The following is a description of a gene set: Human Gene Set: GSE3920_UNTREATED_VS_IFNA_TREATED_ENDOTHELIAL_CELL_DN studied in species Homo sapiens IFNs are highly pleiotropic cytokines also endowed with marked anti-angiogenic activity. In this study, the mRNA expression profiles of endothelial cells (EC) exposed in vitro to IFN-alpha, IFN-beta, or IFN-gamma were determined. We found that in HUVEC as well as in other EC types genes were upregulated (>2-fold increase) by IFNs, including genes involved in the host response to RNA viruses, inflammation, and apoptosis. Interestingly, genes showed a >5-fold higher induction by IFN-alpha in EC compared to human fibroblasts; among them, the gene encoding the angiostatic chemokine CXCL11 was selectively induced by IFN-alpha in EC along with other genes associated with angiogenesis regulation, including CXCL10, TRAIL, and guanylate binding protein 1 (GBP-1). These transcriptional changes were confirmed and extended by quantitative PCR analysis and ELISA; whereas IFN-alpha and IFN-beta exerted virtually identical effects on transcriptome modulation, a differential gene regulation by type I and type II IFN emerged, especially as far as quantitative aspects were concerned. In vivo, IFN-alpha-producing tumors over-expressed murine CXCL10-11, GBP-1 and TRAIL, with evidence of CXCL11 production by tumor-associated EC. Overall, these findings improve our understanding of the anti-angiogenic effects of IFNs by showing that these cytokines trigger an anti-angiogenic transcriptional program in EC. Moreover, we suggest that quantitative differences in the magnitude of the transcriptional activation of IFNresponsive genes could form the basis for cell-specific transcriptional signatures. from publication Indraccolo S, Pfeffer U, Minuzzo S, Esposito G, Roni V, Mandruzzato S, Ferrari N, Anfosso L, Dell'Eva R, Noonan DM, Chieco-Bianchi L, Albini A, Amadori A (PMID 17202376) Genes down-regulated in ndothelial cells: untreated versus interferon alpha., and this is the list of marker genes: KCNK2, PDE2A, PPA1, TMEM154, HARS2, HELZ2, TCOF1 (treacle ribosome biogenesis factor 1), CEP57, CD5, RPL3, DBR1, POLG2, FAM193B, TBC1D16, ATP10A, JAKMIP1, PNPT1, TARS1, ANXA6, LEF1, IL12RB2, NRM, STARD4, ASRGL1, DAXX, TOP2A, LY6D, ELOVL5 (NCBI Gene Id 60481), IFIH1, SPNS3, EZH2, ABTB3, NUDT21, SEC11A, CD69, ZDHHC20, ACSS3, RDH13, ZEB1, LSM14A, NEMP2, PAIP2B, MRPL30, FLNA, TTC39C, GZMM, ANP32E, PRMT5, GABBR1, INO80, RYK, NR3C1, TAF15, JTB, CRYBB3, ETNPPL, SPATA6, FAM53B, GPSM2, IQGAP2, TOMM20, MBNL3, STAT4, GMCL1, IMMP2L, XAF1, FHIP1B, IAPP, PPAT, FNTB, ARHGAP19, IFNGR1, ASB13, SLC7A6, TUFT1, SLAMF1, ZBTB33, SMC3, MAN2A2, TCF12, TBRG1, SLC6A7, ADGRE5, MKI67, CMTR1, MYL4, SETDB2, RPL19, GNAS, ITGB1, CLEC3B, EFHC2, PATJ, KCTD10, NONO, MCM5, SIGLEC15, GTF2I, SMS, ATM (ATM serine/threonine kinase), SLC38A2, KMO, PHF2, DNTT, FLNB, SIT1, ZC3H14, B3GNT2, SEC16B, ATG16L1, NANOS2, POU6F1, ITGB3, SLC14A2, BTLA, EPRS1, SOS1, MPPE1, KRTAP5-1, CDX1, BZW2, PLSCR4, TTC7B, RBBP6, ENTPD5, GFI1, KIRREL2, EVL, XPO7, POLE2, ITPR1 (inositol 1,4,5-trisphosphate receptor type 1), ZHX2, IFIT1, IARS1, HERPUD1, SLC38A8, BBS10, BTBD10 (BTB domain containing 10), TAPT1, MFSD2A, RASGRP1, EMB, MSS51, USP24, ZNRF1, CD82, TMEM150A, LHFPL6, MCM6 (minichromosome maintenance complex component 6), COX6A2, HGSNAT, RORA, CDK5RAP3, RINT1, HOPX, CCR3, KLHL12, OARD1 (O-acyl-ADP-ribose deacylase 1), CCNO, NIBAN1, RBMX, SARS1, REXO1, L3MBTL3, TFAM